The following is a description of a gene set: species: Homo sapiens Atrophy (wasting) of the cerebellar cortex. Cerebellar cortical atrophy Human Gene Set: HP_CEREBELLAR_CORTICAL_ATROPHY, and this is the list of marker genes: TWNK, SC5D, PLAA, SIL1, SNF8, LONP1, ITPR1, ZPR1